Given this list of marker genes NCK2, ROBO2, ROBO1, SLIT1, here is a description of the gene set: Reactome Pathway: Regulation of cortical dendrite branching Besides being involved in axon repulsion during neuronal system development, SLIT-ROBO signaling is also involved in dendrite branching. Based on studies in mice, SLIT1 triggers cortical dendrite branching by activating receptors ROBO1 and/or ROBO2. ROBO effector NCK2 is needed for SLIT1-mediated dendrite branching. species: Homo sapiens part of: Signaling by ROBO receptors